Given this list of marker genes Cacul1, Pou5f2, Osbpl6, Hmgcll1, Mis18bp1, Adgre1, Fsd1l, Lrrc42, Rc3h2, Klhl24, Slitrk5, Foxo3, Fam185a, Gabpa, Cd53, Hoxd3, Reps2, Strap, Btbd1, Fbxo32, Rai2, Scn8a, Eif4g2 (NCBI Gene Id 77989), Vwde, Tead1, Sertad2, Strn, Smco3, Pgrmc2, Frrs1l, Slc40a1, Rab8b, Pcdh20, Dcdc2a, Nfat5, Slc35e1, Chchd6, Onecut2, Tmem70, Spp1, Fut9, Pkn2, Naaladl2, Fam168a, Parp9, Gxylt1, Slc17a2, Rnf169, Slc4a4, Man1a2, Taok1, Pde1c, Kdm5a, Rel, Rapgef4, Tmed9, Nek6, Rbbp5, Amer1, 1700025G04Rik, Fam210a, Usp24, Igf1r, Usp48, Tmed2, Dsg3 (desmoglein 3), Mamld1, Acyp2, Vamp4, Stag2, Slc39a12, Caskin2, Itgb2, Mecp2 (methyl CpG binding protein 2), Gpr4, Mef2a, here is a description of the gene set: from publication Chen Y, Wang X (PMID 31504780) Genes predicted to be targets of miRBase v22 microRNA mmu_miR_7680_3p in miRDB v6.0 with MirTarget v4 prediction scores > 80 (high confidence targets). studied in species Mus musculus Mouse Gene Set: MIR_7680_3P